Given this list of marker genes ALG12, PROC, STX5, COG8, NGLY1, B4GALT1, ALG6, F5, GGCX, PROS1, DPM1, ALG8, DPAGT1, MPI, here is a description of the gene set: An anomaly of the protein C anticoagulant pathway, which serves as a major system for controlling thrombosis, limiting inflammatory responses, and potentially decreasing endothelial cell apoptosis in response to inflammatory cytokines and ischemia. A natural anticoagulant system denoted the protein C pathway exerts its anticoagulant effect by regulating the activity of FVIIIa and FVa. The vitamin K-dependent protein C is the key component of the pathway. Activated protein C (APC) cleaves and inhibits coagulation cofactors FVIIIa and FVa, which result in downregulation of the activity of the coagulation system. The endothelial protein C receptor stimulates the T-TM-mediated activation of protein C on the endothelial cell surface. The two cofactors, protein S and the intact form of FV, enhance the anticoagulant activity of APC. species: Homo sapiens Abnormality of the protein C anticoagulant pathway Human Gene Set: HP_ABNORMALITY_OF_THE_PROTEIN_C_ANTICOAGULANT_PATHWAY